Given this list of marker genes TNFRSF1B, CTLA4, CD28, GSN, FERMT1, here is a description of the gene set: Diffuse skin atrophy Human Gene Set: HP_DIFFUSE_SKIN_ATROPHY studied in species Homo sapiens